Given this list of marker genes Wnt9b, Sost, Gli1, Smad3, Apc2, Lats2, Sdc1, Notch1, Tmem88b, Wnt1, Lypd6, Sox4, Amfr, Dact1, Rspo1 (R-spondin 1), Ptpro, Egf, Hdac1, Tmem198, Tle3, Dab2ip, Hhex, Frmd8, Sdhaf2, Rps12, Lgr5, Gsdma3, Dapk3, Tcf7l1, Nherf1, Gsk3a, Lrp6, Ctnnd2, Eda, Bcl9, Bmal1, Mapk14 (mitogen-activated protein kinase 14), Fzd6, Nfkb1, Tcf7l2, Sfrp2, Rbms3, Xiap, Tnks2, Vps35, Csnk1g1, Bcl9l, Wnt3a, Gskip, Mcc, Vcp, App, Foxo3, Zfp703, Asb3, Shh, Tmem98, Invs, Ruvbl2, Fzd3 (frizzled class receptor 3), Tle6, Tmem131l, Reck, Wnt2b, Daam2, Amer2, Caprin2, Nkd1, Frat2, Stk11, Tmem9, Csnk1a1, Wnk2, Rspo4, Csnk1g2, Dvl3, Sostdc1, Ddx3x, Nphp3, Potefam3a, Sox9, Folr1, Lrp5, G3bp1, Pygo2, Siah1b, Ankrd66, Src, Mks1, Mir135a-2, Ednrb, Zbed3, Znrf3, Siah2, Fzd7, Jrk, Scyl2, Hdac2, Otulin, Disc1, Shisa6, Fzd4, Lrrk2, Tbl1x, Lrrk1, Pten, Cdh2, Adgra2, Cyld, Cdh1, Kpna1, Ppm1b, Apc, Tpbg, Snai1, Frzb, Fgf10, Gpc3, Col1a1, Ndp, Fzd2, Fuz, Amer1, Ube2b, Wnt11, Pfdn5, Rspo3, Prdm15, Spin4, Lgr4, Nppa, Jade1, Fzd10, Wnt8b, Ubr5, Asb15, Csnk1g3, Wnt16, Prickle1, Chd8, Kremen1, Fgfr2, Tle7, Lats1, Mad2l2, Fzd9, Fgfr3, Tmem198b, Ppm1a, Tle2, Potefam3b, Tle5, Wnt2, Tmem88, Rapgef1, Sulf2, Ccdc88c, Dkk2, Fzd1, Dact3, Stk3, Ppp2r3a, Sox17, Usp47, Wnt10a, Ctnnb1, Bambi, Stk4, Rbpj, Gli3, Kank1, Egr1, Wnt3, Cby1, Cdh3, Otud5, Tle4, Dkkl1 (NCBI Gene Id 50722), Atp6ap2 (ATPase, H+ transporting, lysosomal accessory protein 2), Draxin, Adnp, Dlx5, Pin1rt1, Rnf14, Foxo1 (NCBI Gene Id 99758), Trpm4, Mesp1, Tmem64, Usp34, Ttc21b, Snai2, Cthrc1 (collagen triple helix repeat containing 1), Wnt10b, Mllt3, Gnaq, Foxd1, Tpbgl, Nphp4, Wnt7b, Mir135b, Isl1, Rspo2, Sox7, Ednra, Lzts2, Mir135a-1 (microRNA 135a-1), Dixdc1, Nkd2, Wnt7a, Wnt6, Fgf9, Ilk, Ndel1, Ccar2, Mdk, Emd, Fgf2, Tnn, Dab2 (NCBI Gene Id 70555), Lrp4, Tbl1xr1 (NCBI Gene Id 99912), Psen1, Notum, Ptk7, Csnk1e, Cdk14, Nrarp, Ctnnbip1, Grem1, Ppm1n, Tmem170b, Fermt1, Tle1, Pin1, Peg12, Dkk1, Ift20, Sbno1, D1Pas1, Gsk3b (glycogen synthase kinase 3 beta), Lmx1a, Dvl2, Wnt9a, Dkk3, Ctnnd1, Cav1, Smad4, Fzd8, Lef1, Ext1, Ccnyl1, Klf4, Thra, Wnt5a, Sox13, Bmp2, Usp8, Dvl1, Wnt4, Sfrp1, Nog, Ankrd6, Yap1, Wls, Zeb2, Bicc1, Btrc, Wnt8a, Sema5a, Rnf220, Sfrp4, Rnf146, Gprc5b, Amer3, Prkn, Lmbr1l, Nkx2-5, Sfrp5, Frat1, Gpc5 (glypican 5), Fzd5 (NCBI Gene Id 98335), Map3k1, Jup, Dkk4, Egfr, Ccny, Wnk1, Siah1a, Shisa3, Gata3, Csnk1d, Aspm, Tcf7, Ctdnep1, Sox10, Tnks, Col6a1, Axin1, Nle1, Ror2, Ruvbl1 (NCBI Gene Id 66484), Ptpru, Limd1, Wnt5b, Plekha4, Tgfb1, Smad7, Hesx1, Gid8, Rab5a, Ubac2, Axin2, Vps4b, Apoe, Tbx18, Edn1, Ddit3, Scel, Fam53b, Wwtr1, Pygo1 (pygopus 1), Sox2, here is a description of the gene set: studied in species Mus musculus A type of Wnt signaling pathway in which Wnt binding to its receptor on the surface of a target cell results in the by propagation of the molecular signals via beta-catenin, and end with a change in transcription of target genes. In this pathway, the activated receptor signals via downstream effectors that result in the inhibition of beta-catenin phosphorylation, thereby preventing degradation of beta-catenin. Stabilized beta-catenin can then accumulate and travel to the nucleus to trigger changes in transcription of target genes. Mouse Gene Set: GOBP_CANONICAL_WNT_SIGNALING_PATHWAY